Given this list of marker genes Efna1, AA465934, Ggt6, Als2, Myh14, Mir688, Ugt2b34, Fgf1, Ndufs1, Rad52, Pitx2, Rilpl2 (NCBI Gene Id 80291), Gm26611, Fbxo30, Gm19439 (predicted gene, 19439), B230217C12Rik, Clcc1, Gm10062, Ergic3, Slc12a6, Dcakd, Gm16731, Slc15a5, Ciao3, Gm23946, Upp2, Elp5, 2010110E17Rik, Vmp1, Fry, Rexo1, Uroc1, Gm21985, Got1, Smarca2, Arhgap18, Gm9392, Gm28181, Txnl4b, 9130604C24Rik (NCBI Gene Id 77707), Scarna2, Hbp1, Nsun6, Cyp2c37, C130046K22Rik, Neu2 (NCBI Gene Id 23956), Mkx, Tmprss6, Rbbp5, Ppara, Cyp2c39, Tcp11l2, Acox2, Klhdc8a, Serpina1b, Tusc2, Rfx3, F9, Serinc1, Ube3a, C130093G08Rik, Frat1, Prkag2, 1810008I18Rik, Elk4, Gprc5c, Gm25346, Gm28505, Gm24259, R3hdm1, Rnasek, Atp5f1b, Tada1, Zfp91, Cfhr3, St8sia4, Hcfc1r1-ps2, Platr22, Crb3, Nqo2, Scp2, Gpr35, 1500002F19Rik, Dhx38, Immt, Med24, Exph5, Capn10, Nek8, Zfp110, Rptor, Psma3, Nap1l3, Fbxw2, Cables2, Ube2e3, Zbtb2, N4bp1, Gm25526, Prr14, Polg, Mir7684, Runx2os2, Tmcc3, Gm26812, Gm22043, Bckdk, Gm11398, Tnks1bp1, Gstm1, Cited2, P2ry4, Nckap5, Garin2, Nfe2, C9orf72, Plcg1, Ergic1 (endoplasmic reticulum-golgi intermediate compartment 1), Akt1, Cd2ap, Tfap4, Mpped2 (NCBI Gene Id 99312), Psmf1, Marchf2, Spryd4, Arl6ip5, Brca2, Slc26a1, Zfp874a, Il1rn, Mrps18c, Mical2, Gata3os (GATA binding protein 3 opposite strand), Fbxw8, Atf1, Rxrb, Bace1, Grk5 (G protein-coupled receptor kinase 5), Ypel5, Cyp2d9, Mmp25, AI854703, Usp45, Gm29856, E2f3, Rexo2, Ehmt1, 4930577N17Rik, Naa30, Flywch1, Inpp5e, Fmo1, Klf9, Man2a1, Zfp972, Zfp248, Serpinb11, Tfe3, Cbll1 (Casitas B-lineage lymphoma-like 1), Gm12501, Cad, Umad1, Deptor, Gemin5, Chic2, Phkg2, Kdm3b, C920006O11Rik, Paip2b, 1110028F11Rik, Pgap2, Fam124a, Sult2a8, Slc35e2, Anks3, Hpx, Glo1, Gm13975 (NCBI Gene Id 100043219), Trim14, Klhl15, Rack1, Mir6715, Dmgdh, Cyp2a22, Stk32b, Ubxn1, Kxd1, Ccdc28a, Fam169b, Rasa1, Gm16351, Zfhx4, Tmod4, Sardh, Ido2, Prcc, Tmem216, Uqcc6, Cfi, Cnppd1, Ccdc93, 2010109A12Rik, 1810053B23Rik, Gm22122, Fcgrt, Trappc10, Frs2, Crebl2, Sft2d1, Trmt13, Foxp1, Eif4enif1, Smad7, Bcas3os2, A630095N17Rik, Coq3, F730043M19Rik (NCBI Gene Id 320046), Zbtb48, Cbs, Ncoa2, Pdk4, Tram1, Acadm, Tnip1, Psen2, Nisch, Spp2, Aasdh, Dusp16, Gm13056, Mir3073a, Colgalt2, Gm10634, Slc6a12, Gm28818, Cox11, Tmem243, Mtmr14, Klhl18, Mios, Abhd17c, Insig2 (NCBI Gene Id 72999), Zfp949, Sqor, Rmrp, Ctsc, Iqck, Rnf149, Samd8, Nme6, Kif9, Gm19087, Nub1, Cfap276, Meis1, Mir17hg, F2, Cdc25a, Mir17, Gm14016, Mga, Mon2, Slc38a3, Fermt2, Gm24844 (predicted gene, 24844), Kat14, Maml3, Pdxdc1, Fuca1, Per1, Lmo3, Psmb6, Rcc1l, Ric8a, Iqcb1, Igf1, Edem2, Parp2, Pik3ca, Slc40a1, Ap1ar, Ino80c, Snx5, Gm15764, D17H6S53E, Arrb2, Cyp2d40, Cbx8, Trappc3l, Rny3, Utp6, Gcat, Rps6-ps3, Nipsnap1, Cdk2ap2, Xpo7, Ppp2r5e (NCBI Gene Id 66702), Arrdc5, Cfb, Lgi1, Zer1, Knl1, Slc15a4, Gm25489, Mpzl1, Itgal, Mpc2, Extl2, Pip4p1, Trnau1ap, Peli2, Prickle2, Altre, Coa4, Gmeb2, Cdadc1, Sox12, 2210417A02Rik, Dnm3, Hspbp1, Otud7b, Slc2a9, Arih2, Gm15515, Sorbs3, Thbs3, Aldh6a1, Oaz1-ps, Lmo7, Sys1, Ncaph, Ncoa4, Fgb, Scn8a, 9530082P21Rik, Gbp5 (NCBI Gene Id 229898), Tle1, Mtarc1, Serpina1c, Eif2d, Gm15441, Serpina6, Furin, Inmt, Mirg, Rnf214, Snx21, Gm12607 (predicted gene 12607), Slc39a14, Pigr, Ggnbp2, Trim23, Tgif1, Mcm7, Rps7, Serpina1e, Chp1, Capn3, Bok, Wdr5b, Zfpm1, Tdp1, Fbxo46, Acy3, Gbp2, Cfap54, Akt2, Habp2, Gm26747, Klf3, Thg1l, Actb, Wdr73, Fbxl3, H2bc6, Mfsd1, Arsk, Zc3h15, Zfp280b (zinc finger protein 280B), Ccdc71, Gm12739, Hmgb1, Lrrc58, Gm7286, Casp1, Casd1, Egln2, Or2y1, Cblc, Gba2, Ptcd2, Eef1b2, Akt1s1 (AKT1 substrate 1), Pdpk1, Cct8, Otud1, Serpine1, Vps13b, Gata6os, Plekhg2, Rusc2, Kcnu1, Gm12909, Eogt, Mbnl1, Ubn2, Cpn1, Gm9929, H2ac8, Rsrc1, Peg13, Hbs1l (Hbs1-like (S. cerevisiae)), Abtb2, Mat2b, 9030622O22Rik, Cep120, Alkbh8 (alkB homolog 8, tRNA methyltransferase), Nmt1, 9330159M07Rik, Pemt, Gm527, Palld, Grpel1, Dhx37, Gabarapl1, Zfp318 (zinc finger protein 318), H2bc8, Pglyrp3, Tmem203, 6430550D23Rik, Gm2449 (predicted gene 2449), Gm42650 (predicted gene 42650), Epm2a (epilepsy, progressive myoclonic epilepsy, type 2 gene alpha), Gm5431, Havcr1, Optn, Zpr1, 1810019N24Rik, Rpl7l1, Foxp2, Max, Ttc36, H2ac5-ps, Ppp1r15a, Amfr, H3c6, Car14, Igfbp4, Amy1, Ezh1, Pknox1, Sec62, Rps11, Gm34248, Vwa2, Eif3c, Bco2, Antxr1, Itga2b, Intu, Slc17a2, Agrn, Ythdc1, Rassf6, Osbpl1a, Mknk2, Inava, Scaf11, Dcaf6, Vps36, Cyp2b10, A230005M16Rik (RIKEN cDNA A230005M16 gene), Col15a1, Rnf113a2, Nhlrc2, 2610203C22Rik, Abhd4, Dclre1a, Pot1a, Slc2a2, Xpa, Bmpr1b, Flot1, Rasgef1b, Apon, H2ac14-ps, Gm14097, Ubb, Fam114a2 (family with sequence similarity 114, member A2), Syt12, Sgms1, Sh3d19, Hspa13, Mafg, Dnase2b, Gm26019, Qsox2, Dmap1, Paxip1, Lrrfip2, Etv5, Fsip1, Lpin2, Rbpms, Ralgps1, Sephs2, Atp5mc2, Jade1, Tmem143, Psmd7, Cry2, Pcyox1, Rbp1, Rora, Kif20a, Psmb5, Gm29455, Ndufa6, Mir670hg, Ptprd, Mb21d2, Epb41l4b, Yipf4, Tmem259, Rpl29, Depp1 (NCBI Gene Id 71480), Alyref2, Mplkip, Etaa1, Klhdc8b, Ankrd17, Wwp1, Gna14, Serpina1d, Mir3966, Bltp2, Dusp6, E230013L22Rik, Mtarc2, Tspan12, Septin7, Grb2, Wdr46, Pah, Eola1, Nr0b2, 5830411K02Rik, Hexim2, Hdgfl2, Gm12185, Efcab11, Gbp11, Slu7, Zfp874b, Sntb2, Phlda1, 3000002C10Rik, Oxsm, Il6st, Junb, AW146154, C8b, Ces1d, Pgam1, Akr1c14, Hlf, Mxd1, Slc39a7, Mesd, Fkbp5, Atp6v0e, Akap9, Hmgb1-rs16, Cic, Eif4ebp3, Aak1, Phf3, H2bc3, Adipor2, Ndrg2, Gm30270, Zhx3, Flt1, Snord64, Frat2, Aox1, Gm40309, Stag2, Nicn1, Trib1, Tjp1, Gm5370, Pxk, Tlr11, Hnrnpdl, Vwa3b, Wdr48, 2900052L18Rik, Gstt2, Prg4, Gcc2, Pole2, Ldha, Mup20, Gm6939, Polr3b, Taf4, Gm15938, Pag1 (phosphoprotein associated with glycosphingolipid microdomains 1), Ap4m1, Dhx58, Tmx1, Trappc13, Zfp784, Scmh1, Slc41a2, Hacd3, Slc22a26, Rtl9, Cfhr1, Ambp, Tent4b, Rpgrip1, Crtc2, Fam53c (NCBI Gene Id 66306), Gas8, Atf2, Kifbp, Cc2d2a, Bri3, Errfi1, Sdf2, Ifna7, Abcc3, Gtf2a1, Psma4, Fggy, Tbc1d31, Ugdh, Oas1a, 0610039K10Rik, Tnfrsf14, Rsbn1l, Msantd2, 2210406O10Rik, Prps1, Phrf1, Rhobtb1, Gm9967, Il1r1, Hnf1a, Albfm1 (NCBI Gene Id 76092), Tbx3 (T-box 3), C9, Map4, Zbtb20, Aass, Mrpl47, Gm22797, Gcnt2, Bola1, Acsm3, Ropn1l, Nagk, Bet1l, Arpc5, Prdx5 (NCBI Gene Id 54683), Zfp354a, Kiz, 4833421G17Rik, Dnai3, Gpr19, H2-T24, Lrp12, Aacs, Gm26253, Wdsub1, Rpl7, 4930447C04Rik, Klf5, Rita1, Gm12015, Foxq1, Hes1, Traf3ip2, Gas5, Rgp1, Lin52, Sult1d1, Ndufs8, Adgrv1, Slc13a2, Rnf103, Gfod1, Nnmt, Magi1, Ugt2b1, Hgd, Scarb1, Aldoc, Pml, Cxcl1, Sass6, Pnpla8, Gm10827, Itih2, Tpp2, Fcf1, Gm23382, Sugct, Rptoros, Tlcd1, Gm24978, Mob4, Hopxos, Cog3, Atxn7l1, Rbp4, Cnnm3, Rorc, Cyp2a12, Gfpt1, Fgd6, Prdx6, Fezf1, H2bc21, D830025C05Rik (RIKEN cDNA D830025C05 gene), Dctn6, As3mt, Zfyve1, Or5m5, Vcam1, Tmem71, Reep3, Mrpl4, Lyn, Gata6, Il4ra, Ccnd3, Grtp1, Vrk2, Pglyrp2, Pla1a, Fnip1, Ttc33, Trappc9, Slc7a2, Ngef, Gm25438, Zc3hc1, C4bp, Zfp36l2, Eef1a1, Orc4, Acyp1, Gm1818, Tbc1d22a, Psmd4, Ramac, Lamtor4, Nos1ap, D630039A03Rik, Ypel3, Platr14, Eif6, Elp3, Gm11805, Wfs1, Slc35d1, Cutal, Ahsg, Selenop, Nsmce4a (NCBI Gene Id 67872), Aldh4a1, Plg, Rnf39, Ccdc107, Atraid, Atf6, Rwdd3, Pnrc1, Cln8, Ndufs6, Gsdmd, Csn1s2a, Tbc1d17, Asgr2, Apoa5, Gm16754, Mir6236, H4c4, Pfdn6, Dnmt3a, Spen, 2810432F15Rik, Ddx54, Marchf5, A1cf, Setd1a (SET domain containing 1A), Suds3, Shc1, Mrpl44 (NCBI Gene Id 98369), Timm23, Wasf2, Reno1 (regulator of early neurogenesis 1), Slc41a3, Iba57, Slco2a1, Copg1, Fam221a, Rnf114, Retreg2, Thoc3, Plin1, Nfasc, Gm12679, Dnaaf9, Capn15, Oxa1l, Dleu2, Gtf2i, Bcas3, Btf3-ps2, Mroh1, D630024D03Rik, Gm16016, Trim28, Adcy10, Cyp2d26, Prkar2a, Prkrip1, Ralbp1, Ctsa, A930009A15Rik, Sdc4, Med13l, F13b, Bptf, Got2, Coq10b, Gm29340 (predicted gene 29340), Pop1, Col18a1, 9230111E07Rik, E130102H24Rik, Paics, Fetub, Dmtn (NCBI Gene Id 13829), Gm15471, Rnf157, Entpd5, Uox, Dnttip2, Lrrc3c, Agmo, Chmp6, Dbpht2, Dapk1, Skic3 (SKI3 subunit of superkiller complex), Hes6, Lrg1, H2bc18, Lbp, Mast2, Rmnd5a, Stx12, Abhd5, Txnip, Mrpl45, Smarcad1, Med23, Ndufaf1 (NADH:ubiquinone oxidoreductase complex assembly factor 1), Lrfn5, Apob, Zcwpw2, Uba2, Gm15411, Trf, Evi5l, Tbrg4, Gm5248, Ndor1, Bmp6, 1810010H24Rik, Ect2, Ercc3, Gm16150 (NCBI Gene Id 102638318), Rif1, Apoa2, Necab1, Gys2, Or1e29, Dnajc24, Dmxl1, Klf7, Slc66a2, Rpl9-ps4, Srsf12, Lrp1, Fancc, Mpzl2, Mpeg1, 1700125G22Rik, Foxa2, Gm15663, Gm7457, Lrp2bp, Rpph1, Psd4, Mon1a, A630076J17Rik, Gm2093, Tent5b, Mrpl16, 4930556N13Rik, Rabgap1, Zswim4, Atp5mj, Trpv2, Ssh2, Prkn, Ccni, Rbm6, Mup3, Eif1, Gm18901, Saa4, Scaf8, Hsd17b2, Tmem140, Agbl5, Rpl22, Tenm4, Dcdc5, Olig1, Anxa3, Six6, Eif4g3, Macrod1, 4930551O13Rik, Zfp282, D830032E09Rik, Zfp395 (NCBI Gene Id 407796), Arhgap12, Socs2, Mafk, Mospd4, Ncapd3, Wdr45, Lsm6, Hibadh, Tgtp1 (T cell specific GTPase 1), Vps26b, C1rl, Pxn, Cryzl1, Sos2, Rdx, Ccne2, Cps1, Tsc22d4, Slc1a3, Rtp3, Fgl1, Baz2a, Cox20, Srsf10, Rbbp6 (retinoblastoma binding protein 6, ubiquitin ligase), Dcaf11, Slc36a4, Arid2, Trmt112, Gm16120, Ccr9, Tymp, Neurl2, Abcd2, H2-K1, Syngr4, Dsc2, Dram2, Nav3, Pi4k2a, here is a description of the gene set: Mouse Gene Set: FOXA3_TARGET_GENES Genes containing one or more binding sites for (Foxa3) in their promoter regions (TSS -1000,+100 bp) as identified by GTRD version 20.06 ChIP-seq harmonization. from publication Yevshin I, Sharipov R, Kolmykov S, Kondrakhin Y, Kolpakov F (PMID 30445619) species: Mus musculus